The following is a description of a gene set: studied in species Homo sapiens Human Gene Set: GOBP_GONADAL_MESODERM_DEVELOPMENT The process whose specific outcome is the progression of the gonadal mesoderm over time, from its formation to the mature structure. The gonadal mesoderm is the middle layer of the three primary germ layers of the embryo which will go on to form the gonads of the organism., and this is the list of marker genes: TSPY9, TSPY2, TSPY4, TSPY8, TSPY1, TSPY10, ZFPM2, AMH, TSPY3